Given this list of marker genes Batf, Ifi47, Aars1, Idnk, Ppa1, Dad1, Iigp1, Ptpn1, Gpr171, Il21r, Slc49a4, Ssh2, Ftl1, Grk6, Gadd45g, Ablim1 (actin-binding LIM protein 1), Trib2, Lsm4, Nfkbia, Eif1, Arid5a, Vps37b, Crem, Kbtbd11, Nup210, Rnf19a, Isg15, Isg20, Gpr146, Skap2, Crlf2, Mthfd2, Lpp, Stt3b, Ly6e, Runx3, Trac, Ssbp4, Vars1, Gngt2 (NCBI Gene Id 14710), Serinc3, Eif2s2, Samhd1, Gramd2b, Jund, Socs1, Sdf4, Mapkapk2, Itpk1, Ldha, Eif5a, Gbp2, Etv6 (ets variant 6), Ly6a (NCBI Gene Id 17065), Zfp36l2, Zfp281, Sbno2, Txnip, Cblb, Apobec3, Rtp4, Zc3hav1, Ube2s, Mfsd6, Treml2, Tnfrsf18, Tap1, Tcf7, Hif1a, Stat3, Ppp1r16b, Btg1 (NCBI Gene Id 380657), Arl6ip5, Mrpl52, Irf7, Cd53, Pgs1, Zbp1, Myl12b, Gtf2a2, D8Ertd738e, Rapgef6, Parp14, Gpr18, Ankrd11, Ndrg3, Socs3, Gpr65, Cdkn2d, Arl5a, Igfbp4, Ifi27l2a, Chmp4b, Psme2, Arid5b, Kif1b, Cd47, Myd88, Tsc22d3, Cytip, Epb41, Ifngr1, Psme1, Parp9, Tnfaip3, Il4ra, Crybg1, Flot1, Bst2, Pja1, Mxd1 (NCBI Gene Id 17119), Rnf213, Helz2, Bcl3, Sgk1, Pmepa1, Elovl6, Dtx3l, Satb1, Trim30a, Eeig1, Fkbp5, Psmb10, Arap2, Stat1, Birc3, Pim1, Mcl1, Tut4, here is a description of the gene set: from publication Cui A, Huang T, Li S, Ma A, Pérez JL, Sander C, Keskin DB, Wu CJ, Fraenkel E, Hacohen N (PMID 38057668) Genes positively differentially expressed in cell type: CD4+ T cell upon treatment with cytokine: IL-1α in mouse lymph nodes in vivo. Mouse Gene Set: CUI_T_CELL_CD4_IL1A_RESPONSE_UP Cytokines mediate cell-cell communication in the immune system and represent important therapeutic targets. A myriad of studies have highlighted their central role in immune function, yet we lack a global view of the cellular responses of each immune cell type to each cytokine. To address this gap, the authors created the Immune Dictionary, a compendium of single-cell transcriptomic profiles of more than 17 immune cell types in response to each of 86 cytokines (>1,400 cytokine-cell type combinations) in mouse lymph nodes in vivo. A cytokine-centric view of the dictionary revealed that most cytokines induce highly cell-type-specific responses. For example, the inflammatory cytokine interleukin-1β induces distinct gene programmes in almost every cell type. A cell-type-centric view of the dictionary identified more than 66 cytokine-driven cellular polarization states across immune cell types, including previously uncharacterized states such as an interleukin-18-induced polyfunctional natural killer cell state. studied in species Mus musculus